Given this list of marker genes PRKCB, STXBP3, PRKCG, PRKCA, STX4, here is a description of the gene set: species: Homo sapiens Disinhibition of SNARE formation Human Gene Set: REACTOME_DISINHIBITION_OF_SNARE_FORMATION